Given this list of marker genes USP6, FAM81A, PTK2B, TNIK, CTNNB1, FYN, GRIA1, ACTN2 (NCBI Gene Id 88), GRID2IP, CRIPT, SH3GL3, CTNNA2, PRR7, BAIAP2, PSD, CFL1, SLC30A1, FABP5, here is a description of the gene set: studied in species Homo sapiens Human Gene Set: GOCC_POSTSYNAPTIC_DENSITY_INTRACELLULAR_COMPONENT A network of proteins adjacent to the postsynaptic membrane forming an electron dense disc. Its major components include neurotransmitter receptors and the proteins that spatially and functionally organize neurotransmitter receptors in the adjacent membrane, such as anchoring and scaffolding molecules, signaling enzymes and cytoskeletal components.